Given this list of marker genes PAK4, TIAM1, DOCK10, CDC42, BCR, NCF1, IL32, ARHGAP42, ARHGAP32, CYFIP1, CDC42EP1, RAPGEF1, OPHN1, SLITRK3, ARAP2, EPHA2, BAIAP2L1, ERBIN, BAIAP2, TMPO, SNAP23, SWAP70, PREX1, VAV2, ABR, ESYT1, ARHGAP21, SLITRK5, NOX1, NCKAP1, RAB7A, DEPDC1B, ARHGAP35, PIK3R2, NCKAP1L, AMIGO2 (NCBI Gene Id 347902), ARHGAP6, DSG2, VAMP3, RAC3, ITGB1 (integrin subunit beta 1), SLC1A5, ARHGAP39, WASF1, SRGAP2, DIAPH3, GARRE1, LAMTOR1 (late endosomal/lysosomal adaptor, MAPK and MTOR activator 1), ARAP3, TAOK3 (NCBI Gene Id 51347), ARHGAP15, VRK2, PGRMC2, LBR, ARHGAP17, RACGAP1, SYDE1, PAK2, GIT1, ARHGAP5, ABI1, ARHGAP26, ABI2, MCF2, TFRC, ABL2, VANGL1, YKT6, NOX3, STBD1, GIT2, NCF4, MPP7, CYBA, OCRL, NCF2, MCAM, TRIO, CYBB, CAV1, WASF2, FERMT2, ARHGDIB, NHS, NOXA1, BRK1, JAG1, ARHGAP1, PIK3R1, PAK1, EMD, LMAN1, NOXO1, LEMD3, here is a description of the gene set: Reactome Pathway: RAC3 GTPase cycle part of: RHO GTPase cycle species: Homo sapiens This pathway catalogues RAC3 guanine nucleotide exchange factors (GEFs), GTPase activator proteins (GAPs), GDP dissociation inhibitors (GDIs) and RAC3 effectors. RAC3 is highly similar to RAC1 (92% amino acid sequence identity), but it is expressed in fewer tissues than RAC1. RAC3 orthologues only exist in vertebrates (de Curtis 2019). RAC3 is highly expressed in neurons and plays an important role in neuronal and brain development (de Curtis 2014, de Curtis 2019). RAC3 mutations have been reported in patients with intellectual disability and brain malformations (de Curtis 2019). RAC3 is frequently overexpressed in cancer and contributes to proliferation, migration and invasiveness of cancer cells (de Curtis 2019).